Given this list of marker genes JPH3, ERO1A, FCRL3, SNAP25, NOL3, SLN, REP15, WNK4, SESTD1, IFNG, CHD7, ATP2B4, KCNH7, KCNK15, KCNG2, KCND3, CNNM4, TRPA1, SIK1, FLNA, CACHD1, KCNRG, ORAI1, SCN4A, TFR2, KCNJ10, SLC6A8, TMC2, MIR34A (microRNA 34a), KCNT2, KIF5B (NCBI Gene Id 3830), ATP1A3, TRPC6, ZDHHC13, FGF2, NDFIP1, SLC25A28, GRP, MRS2, CYBA, SPTBN4, CCR1, SLC11A1, CAB39, TRPM1, DMPK, CUTC, SLC8A1, TRPV5 (NCBI Gene Id 56302), ITGAV, SLC9B2, SLC38A1, ANK2, TMCO1, SLC5A7, STRIT1, SELENON, PTPN6, HAP1 (NCBI Gene Id 9001), ATP1A2, SLC4A7, EGF (NCBI Gene Id 1950), FXYD3, KCNK9, SLC12A7, HTR2B, CDK2 (NCBI Gene Id 1017), SLC9A9, SLC12A4, ITPR2, BAK1, NGF, TMBIM1, MIR208A, CALCA, KCNJ14, RAMP1, CCL2, LILRA5, TMEM94, KCNN4, MIR499A, CTNNB1, KCNK18, CATSPER3, KCNJ15, LILRA2, SLC6A4, FXYD6, UBASH3B, DPP10, PDE4B, CRACR2A, SLC25A37, TF, SLC39A2, SLC41A3, MIR29B1, CALM1, TRPV2, GCG, TMEM175, P2RX3, SPG7, NKAIN4, TRPM6, CLIC2, LARGE1, SLC6A18, CASK, CACNA2D3, WNK1, SLC6A1, UBQLN1, MCOLN2, SLC10A4, TMEM37, JPH4, AMIGO1, IL16, PLCG2, KCNJ11, GP1BB, SLC4A10, SLC6A16, CDK5, KCNS1, SLC9A3, EDNRB, PRKCE, KCNE1, KCNK2, SLC35G1, KCNQ1, WWP2, SLC17A3, LRRC38, AKAP6, CX3CL1, HPN, ATP2C1, MCU, CCDC51, KCNA7, KCNE4, KCNIP3, GRXCR1, TGFB1, NTSR1, LETM2, NKAIN2, MIR26A1, PANX1, NDFIP2, KCNS3, OPRK1, CNTN1, OXSR1, KCNK12, AHCYL1, SLC5A1, NOS3, SLC9A7, KCNQ3 (potassium voltage-gated channel subfamily Q member 3), MIR448, SLC12A8, KCNJ2, VPS4B, AHNAK, TMEM165, KCNMB3, SCN4B, HTT, ZMPSTE24, TPCN2, FTH1P19, SLC39A13, CAMK2D, KCNK6, CLTC (clathrin heavy chain), CRH, EPO, SLC3A2 (solute carrier family 3 member 2), KCNK7, PSEN2, ABCB8, EPM2A, MICU2, CACNA1E, LRRC26, KCNV1, MMGT1, SFXN1, CACNB3, LYN, FMR1, KCNIP2, KCNJ18, SLC38A3, MIR1-1, RYR1, PKD1L2 (polycystin 1 like 2 (gene/pseudogene)), CACNG3, SLC20A1, NIPAL4 (NIPA like domain containing 4), CXCL11, NIPAL3, SMDT1, CNGA4, CHRNA9, NALF1, GRIN2D, SRI, WNT3A, RGS9, CNGA3, SLC6A5, ITGB3, BAX, FTMT, PMPCB, PPP3CA, SCN3A, BDKRB1, NCS1, FHL1, PTPRC, PKD2L1, PPP3CC, MRLN (NCBI Gene Id 100509305), SLC24A4, CSN2 (NCBI Gene Id 1447), MLLT6, CCT8L2, ASPH, FGF13, TMBIM4, COX17, CAPN3, CRHR1, FGF12, MFSD4B, SLC10A7, CEMIP, KCNH1, LETM1, SLC5A9, NPPA, KCNC4, PLCE1, FXYD7, VDAC1, SLC1A3, XCL1, ADORA2A, ADCYAP1R1, ATP1B1, LPAR3, HES1, TRPC4AP, KCNA1, FXYD2, PPP3R2, SLC30A7, SLC4A4, SHROOM2, NOS1AP, ATG5, NALCN, DRD3, SLC39A11, MAGT1, PLN, FTHL17, SLC17A4, KCNJ16 (NCBI Gene Id 3773), SLC10A6, SCNN1B, STEAP3, CDKN1B, CACNG7, LCK, CATSPER4, MIR103A1, ATOX1, MIR212, ANO9, MYLK, SLC8A2, SLC12A3, CHRNA4, SCN3B, CATSPER2, CHRNA10, SLC24A2, KCNMB1, SLC13A4, LRRC55, STAC2, TRPC4, GRIN2B, KCNA5, ISL1, CXCR3, KCNN3, SLC34A2 (solute carrier family 34 member 2), TRPV4, GRIN2A, SLC13A3, ITPR3, FAIM2, GRIN2C (NCBI Gene Id 2905), ABL1, KCNJ1, SCN2A, TOR2A, GALR2, CACNA1I, SLC8B1, HCN2, CACNA2D4, SLC41A1 (NCBI Gene Id 254428), CUL5, P2RX7, KCNK16, KCNA2, AP3D1, NIPSNAP2, EPB41, P2RX6, SCN2B, CAMK2A, SLC23A2, SLC5A2, KCNF1, ABCC9, SLC6A11 (solute carrier family 6 member 11), KCNH6, METTL21C, EDNRA, RYR3, KCNIP1, P2RY6, CNNM2, PLA2G1B, OSR1, SLC8A3, APLNR, CACNG1, SLC6A6, RAB11B, CBARP, SLC22A17, CD19, KCNQ5, ATP1B4, STIM1, SLC4A5, SLC13A5, KCNJ6, SLC25A23, CCR5, NEDD4L, SLC10A1, SLC4A8, KCNB2, KCNH3, CACNA1C, SLC5A4 (NCBI Gene Id 6527), SLC22A4, HEPH, LRP2, INPP5K, NOS1, ORAI2, SLC6A20, SLC9A4, KCNJ8, CHRNA7, PLCL1, LRRC52, SLC9A8, KCNV2, PLCG1, PLCB1, KCNK17, CREB3, HOMER1, MIR210, WNK2, KEL, KCNG4, DHRS7C, KCNJ4, SCN8A, HOMER2, KCNE5, TMBIM6, SLC17A2, ATP4B (ATPase H+/K+ transporting subunit beta), CORO1A (NCBI Gene Id 11151), TRPV1, CALHM2, SGK1, KCNK3, YWHAE, CD4, PLCL2, KCNA6, B2M, TUSC3, PLCB4, HCRT, CAV3, CXCL10, KCNQ4, NIPAL2, ATP1A4, VAMP2 (vesicle associated membrane protein 2), KCNK13, MCUB, JPH1 (NCBI Gene Id 56704), KCNG3, DIAPH1, TSPO, PRKACA, ASIC1 (NCBI Gene Id 41), HTR2A, LGALS3, SLC9A5, KCNT1, P2RX1, HRC, SLC9C2, UMOD, FASLG, KCNIP4, GHITM, SLC5A6, SLC6A15, ATP2B1, RYR2, CDH23, KCND2, STEAP2, TLR9, SLC30A3, SCNN1D, TRPV3, SLC1A1, REM1, BHLHA15, SLC24A3, FKBP1A, SCN7A, PDGFB, SLC9A2, HAMP, ISCU, SLC39A4, SLC6A12, KCNK1, FLVCR1, CASR, CD63, SLMAP, ACTN4, KCNJ3 (NCBI Gene Id 3760), NKAIN1, PSEN1, F2, KCNE3, RAMP2, ABCC5, ASIC3, THY1, KCNN1, SLC6A7, SLC39A10, ATP7A, CYP27B1, CCL3, NALF2 (NALCN channel auxiliary factor 2), KCNU1, CACNG4, SLC39A14, SLC39A6, UTRN, SRL, GCK, UCP2, TSC1, CASQ2 (calsequestrin 2), SEMG1, ATP2A1, SLC5A5, MAGED2, PTK2B, P2RX5, PRKCB, CACNA2D1, ARHGAP1, KCNN2, MIR133A1, SLC34A1, SLC6A13, KCNJ13, GNAI2, PRSS8, SLC30A9, LCN2, FLVCR2, GRIN3B, TRPM4, PACSIN3, SLC24A1, NSF, SLC39A1 (solute carrier family 39 member 1), TMEM38A, MIR328, CBLIF, ATP1A1, PON3, FXYD6P3, CACNG2, TPCN1, RAMP3, PCSK9, SCNN1A, SCNN1G, TESC, ITPR1, TRPM3, KCNK4, HCN4 (NCBI Gene Id 10021), KCNAB3, DRD2, HCN1, PDPK1, ADORA1, TRPM7, OPRM1, STAC3, PLCB2, ACTN2, STIM2, JPH2, STC1, CCR7, CAMK2B, SLC10A5, RGS4, KCNK10, CCL19, CACNB2, PDGFRB, SCN1A, EDN3 (NCBI Gene Id 1908), PLCZ1, ITPRIPL1, TRPM5, CCL8, GSTM2, NECTIN1, ASIC5, DNM2, PLCH1 (NCBI Gene Id 23007), SCARA5, ASIC4, NKX2-5, SLC38A2, KCNMA1, ATP12A, CHRNB2 (NCBI Gene Id 1141), SARAF, KCNE2, ABCC8, SLC30A10, LILRB2, GAL, CACNG8 (calcium voltage-gated channel auxiliary subunit gamma 8), KCNJ5, HOMER3, CALHM3, GRIN1 (glutamate ionotropic receptor NMDA type subunit 1), SLC9A1, PKP2, MIR208B, SLC12A2, GRM6, GSTO1, SLC39A9, PKD1L3, SLC24A5, GNB2, SLC17A7, CALM2, MCUR1, TRPC1, SLC31A1, F2RL3, TRPM2, TMEM163, SNTA1, CHERP, MAIP1, CACNA2D2, TRPM8, BCL2, ATP6V1B1, TTYH1, ORAI3, CALHM1, ATP2A2, AQP1, CHP1, GUCA2B, DLG1, GAS6, TRDN, APP, CCL21 (NCBI Gene Id 6366), TMCO3, PANX3, HFE, GPR35, CLCNKB, MIR24-1, TRIM27, MIR21, BPIFA1, SLC46A3, TMX1, IBTK, MIR424, SLC6A9, KCND1, SCN9A, IL13, CACNB4, CACNA1S, WNK3, PRNP, GNB5, ADRB2, SLC39A8, SLC6A14, NHERF1, COMMD9, TFRC, SLC13A2, PRKD1, SLC41A2, KCNC1, KCNC2, MS4A1, PLCH2, KCNJ12, KCNK5, SEC61A1, PLCB3, SLC4A9, MIR200C, SLC12A5, ATP1B2, CACNG5, STC2, AKAP5, CNGB1, SLC17A1, TPT1, CALM3, SLC13A1, SLC5A10, NKAIN3, ADRA2A, VDR, SLC12A6 (solute carrier family 12 member 6), CXCL9, EDN1, TRPC7, KCNA4, FTH1, TMC1, SLC39A7, CASQ1, SCN5A, GRAMD2A, SLC38A11 (solute carrier family 38 member 11), WFS1, SLC23A1, SLC38A4, SLC30A1, SLC4A11, GP9, KCNAB1, SLC9C1, MCOLN1, FKBP1B, CNGA1, SLC46A1, AFG3L2, STEAP4, GP5, LTF, SLC38A7, HPCA, FYN, VMP1, PER1, PTPN3, HEPHL1, DDIT3, PKDREJ (polycystin family receptor for egg jelly), CLDN16, OPRD1, FXYD1, HSPA9, ATP2B2, SLC34A3, TREM2, PIK3CG, CAMK2G, CACNB1, SCN1B, HTR2C, KCNJ9, SNCA, SLC9B1, SLC39A12, PKD2L2, MELTF, TSPAN13, SCN10A, PDE4D, SLC12A9, SLC5A12, ATP4A, SLC38A5, CXCL12, SLC30A5, LILRB1, TCN1, SPINK1, KCNAB2, SELENOK, BIN1, GRINA, SLC17A8, UCN, KCNC3, STK39, ATP2C2, RANGRF, SCN11A (NCBI Gene Id 337933), ABCB6, CCL5, MIR30D, SLC22A5, F2R, ATP1B3, KCNA10, KCNS2, SUMO1, DRD1, SLC11A2, GJA5, SLC5A8, TRPC3, SLC6A19, MIR192, SLC12A1, MICU1, SLC6A17, P2RX4, KCNA3, CNKSR3, ATP7B, BEST1 (bestrophin 1), COMMD3, GRIN3A, SLC30A2, MIR93, SLC30A6, LACRT, SLC39A3, ATP13A1, SLC9A6, PPP3CB, ATP2B3, RCVRN, SPG11, SLC30A8, PKD1, GPM6A, SLC40A1, FXYD4, STIMATE, MICU3, TRPC5, MYB, KCNMB2, PLPP4, PPP3R1, CAV1, SLC17A6, YWHAH, TRPV6, KCNB1, CYBRD1, SLC6A2, EFHB, PKD1L1, CALCRL, EPPIN, KCNH8, FKBP4, KCNH4, CYSLTR1, ANXA6, CRACR2B, CACNA1F, ANK3 (NCBI Gene Id 288), SLC48A1, BSPRY, LIME1, SLC10A2, KCNQ2, HCN3, AKAP7, DMD, SLC6A3 (solute carrier family 6 member 3), MT3, ATF4, NIPA2, KCNG1, TMEM38B, PML, ASIC2, SLC5A3, FTL, SLC5A11, XCR1, CD84, MCOLN3, P2RX2, NIPAL1, PKD2, CACNA1B, ABCB7 (ATP binding cassette subfamily B member 7), CACNA1D, SLC28A3, ATP2A3, KLHL3, FXYD5, SERPINE2, CLCA1, NEDD4, FFAR1, DPP6, NDUFA9, STAC, DNM1L, LMTK2, AGT, CCL4, CATSPER1, GPER1, NIPA1, TCN2, FXN, SLC30A4, KCNH5, PGRMC2 (progesterone receptor membrane component 2), HPX, CACNA1A, GPD1L, NPSR1, SLC25A25, CACNG6, GP1BA, ANO6, CNGA2, AKT1, SLC39A5, SLC20A2, KCNH2, SLC31A2, G6PD, COMMD1, CACNA1H, UBR3, KCNMB4, MCHR1, CACNA1G (NCBI Gene Id 8913), here is a description of the gene set: The directed movement of metal ions, any metal ion with an electric charge, into, out of or within a cell, or between cells, by means of some agent such as a transporter or pore. species: Homo sapiens Human Gene Set: GOBP_METAL_ION_TRANSPORT